The following is a description of a gene set: Human Gene Set: GOMF_PROTEIN_PHOSPHATASE_1_BINDING Binding to a protein phosphatase 1. species: Homo sapiens, and this is the list of marker genes: AKAP11, PPP1R3A, PPP1R11, SMTNL1 (smoothelin like 1), SHOC2, LILRB2, KCNQ1, PPP1CC, STAU1, PPP1R10, PPP1R15A, PHACTR4, PPP1R3C, PPP1R3E, LILRB1, PPP1R3F, FER, TPRN, ADISSP, DYNLT4, SH3RF2, PPP1R3B, PPP1R3G, PPP1R3D, PPP1R9B, PPP1CA